The following is a description of a gene set: Genes down-regulated in thymic macrophages versus medullary thymic epithelial cells (mTEC). species: Homo sapiens Human Gene Set: GSE2585_THYMIC_MACROPHAGE_VS_MTEC_DN Gene expression in different thymic stromal cells and subsets thereof was analyzed in 6-12 week old wild type (C57BL/6) and Aire knock-out (mixed background) mice. Thymic stromal cells were purified by sequential enzymatic digestion (collagenase, collagenase/dispase and trypsin) followed by gradient centrifugation and FACS sorting. Sort criteria were as follows: dendritic cells (CD11c+, F4/80 -), macrophages (F4/80+, CD11c-), cTECs (CD45–/lo, CDR1/Ly51+, Ep-CAM+) and mTECs (CD45–/lo, CDR1/Ly51–, Ep-CAM+). mTECs of wild-type and Aire knock-out mice were further subdivided according to CD80 expression levels. For microarray analysis total RNA from thymic stromal cell samples of two independent experiments was pre-amplified and biotinylated by two rounds of cDNA synthesis and in vitro transcription. Fluorescence readings were evaluated by using Microarray Suite 5.0 software. from publication Derbinski J, Gäbler J, Brors B, Tierling S, Jonnakuty S, Hergenhahn M, Peltonen L, Walter J, Kyewski B (PMID 15983066), and this is the list of marker genes: MIR22HG, KCNJ15, ATP2B4, LINC00390, CACNA2D3, EPS8L2, FRAS1, RNF8, DIRAS2, TOM1L1, TSPAN6, MPO, OSGEPL1, ST8SIA5, GZMH, TAS2R14, TDRD12, MYCL, RABL6, S100A10, H2AZ1, CEP152, LTA4H, PEX13, SEMA6D, LUZP4, RNMT, KIR2DS3, PRR13, DCAF1, CDO1, SLAMF1, PDE4B, CCL4, RUBCNL, CCR7, MACO1, GSTA1, BNC2, PTH2R, SNX16, IFNG, ENTPD1, LINC00574, PPP1R3A, ADAMTS5, PMP22, SLC2A3, COG5, ARID5B, PREPL, NFIL3, TUBGCP4, GALNT10, AKAP6, CORO1C, LRRC17, TBL1XR1, PSMB7, FETUB, TCF4, PMEPA1, SPACA1, EVPL, INSL4, TSBP1, GTF3C4, FLVCR2, SIGLEC15, LEP, PRKCB, NEB (NCBI Gene Id 4755), CLEC2D, CD300A, SLC43A3, ZBED2, SLFN12, STATH, LPL, MST1R, PCCB, H3C6, PPFIA4 (NCBI Gene Id 8497), DCAF4 (NCBI Gene Id 26094), RET, JUN, RAB20, LRP5L (NCBI Gene Id 91355), FLOT1, PDZRN4, SETBP1, INSIG2, NSUN7, GRPEL1, ST3GAL2, GALNT3, OTULINL, FMO6P, ARFIP2, PIM1, PPFIA1, PGLYRP4, PLAGL2, CYTIP, RNF24, LIF (NCBI Gene Id 3976), TBX21, PEX3, CPB1 (NCBI Gene Id 1360), GARS1, DDIT4, VEGFD, IL12RB2, MSR1, SLC7A11, RIBC2, VEGFA, SEMA4D, CFAP298, BCL9, DARS2, CCDC170, INTS9, DNASE1L1, GLO1, IQSEC1, ZFX, ZNF253, TEC, KYAT3, SI, HYAL4, PDE5A, PLCG2, AARS1, PIGA, PRKAA1, GABRA2, CIB1, CTAGE11P, PSTPIP1, UFSP2, CDC123, HOOK2, PSMA1, CASP9, HK1, PXN, PRIM2, FAM184A, LRRC20 (NCBI Gene Id 55242), BNIP3, DEDD, RADX, MLH3, PPBP, NAB1, CMKLR2, ATP6V1B2, TLCD3A, ARK2N, HECTD3 (HECT domain E3 ubiquitin protein ligase 3), APOC3, PFDN2, GPR50 (NCBI Gene Id 9248), PEX19, UBQLN3, COA1, CDKL1, SCD5, SERPINB1, AURKC, XRCC5, MTMR7, RELA, INHBE, KLHL28, CDKN1A, PIAS3, SNU13, KCNS3, DOK5, MECP2, NBEA, LGALSL, KDM4D, ESRP1, DMXL2, CXCL13, EFHC1, IL18RAP, EPS8L3, TFRC, CYREN, TCOF1, ISG20, MEA1, RFX7